Given this list of marker genes TMEM72, ATP1A1, ROCR, ANXA4, HSD3B7, KIF12, ANXA9, IFFO2, TMEM141, OR5G5P, SFRP5, SCTR (secretin receptor), MNX1, ADAMTS16, GPR3, LEFTY1, ACBD4, CALB1, CFTR, NEURL1, CALHM3, FGFR3, LRRC75B, CCN2, LINC01152, RNU6-287P, CLDN9, ZBED3, HHEX, PPP1R1B, H3-3B, RABGEF1P1, CYS1, KLHDC7A, CHDH, SUCLG1, FBXO21, SLC4A4, GS1-24F4.2, SALL4, GSTK1, CBX3P2, ADORA1, RASSF7, ID4, CITED4, FAM245A, FXYD6-AS1 (NCBI Gene Id 123706543), MPND, HES4, LZTS3, CLDN10, HEY1, ART3, NEURL1-AS1 (NCBI Gene Id 102724341), LCIIAR, PDE3A-AS1, ENSG00000272384, NRTN, GREP1, MNX1-AS2, LINC01829, LINC01220, GSTM3, GMCL1, OGDHL (oxoglutarate dehydrogenase L), PRKAR1B-AS2, PUF60, ISYNA1, GMNN, FXYD2, here is a description of the gene set: studied in species Homo sapiens Marker genes curated from the annotated cluster as represented in the Descartes Human Gene Expression During Development database. Human Gene Set: DESCARTES_MAIN_FETAL_DUCTAL_CELLS from publication Cao J, O'Day DR, Pliner HA, Kingsley PD, Deng M, Daza RM, Zager MA, Aldinger KA, Blecher-Gonen R, Zhang F, Spielmann M, Palis J, Doherty D, Steemers FJ, Glass IA, Trapnell C, Shendure J (PMID 33184181) The gene expression program underlying the specification of human cell types is of fundamental interest. The study authors generated human cell atlases of gene expression and chromatin accessibility in fetal tissues. For gene expression, the study authors applied three-level combinatorial indexing to >110 samples representing 15 organs, ultimately profiling ~4 million single cells. The study authors leveraged the literature and other atlases to identify and annotate hundreds of cell types and subtypes, both within and across tissues. Our analyses focused on organ-specific specializations of broadly distributed cell types (such as blood, endothelial, and epithelial), sites of fetal erythropoiesis (which notably included the adrenal gland), and integration with mouse developmental atlases (such as conserved specification of blood cells). These data represent a rich resource for the exploration of in vivo human gene expression in diverse tissues and cell types.